Given this list of marker genes EMILIN1, F11R, IL6, CTSG, MMRN1, IL6R, JAK2, MFSD2B, HTR2A, PDPN, EMILIN2, IL6ST, GP6, here is a description of the gene set: Human Gene Set: GOBP_POSITIVE_REGULATION_OF_PLATELET_AGGREGATION Any process that activates or increases the frequency, rate or extent of platelet aggregation. Platelet aggregation is the adhesion of one platelet to one or more other platelets via adhesion molecules. studied in species Homo sapiens